Given this list of marker genes Ch25h, Msmo1, Cmah, Faxdc2, Degs2, Cyp27a1, Fa2h, Tyr, Tyrp1, here is a description of the gene set: Catalysis of an oxidation-reduction (redox) reaction in which hydrogen or electrons are transferred from each of two donors, and one atom of oxygen is incorporated into one donor. studied in species Mus musculus Mouse Gene Set: GOMF_OXIDOREDUCTASE_ACTIVITY_ACTING_ON_PAIRED_DONORS_WITH_INCORPORATION_OR_REDUCTION_OF_MOLECULAR_OXYGEN_ANOTHER_COMPOUND_AS_ONE_DONOR_AND_INCORPORATION_OF_ONE_ATOM_OF_OXYGEN